Given this list of marker genes Lama2, Glipr1l1 (GLI pathogenesis-related 1 like 1), Tspan32, Ctla4, Nrxn1, Itga10, Itga11, Itgb4, Itgal, Itgad, Nid1, Mmrn1, Itga2b, Cd28, Itgb6, Itgam, Lgals1, Jam2, Nlgn1, Itgax, Itgb1, Itgb8, Lamb2, Itga9, Emilin1, Plp1, Lamc1, Itgb2, Itga1, Tnn, Vtn, Itgb7, Lama1, Lyn, Tnc, Emilin2, Lgals2, Itgav, Itgbl1, Plau, Cd80, Itga4, Itga7, Itga6, Itgb5, Izumo1, Itgb2l, Plaur, Pmp22, Tnr, Itga2, Jam3, Itgb3, Itga3, Mmrn2, Lamb1, Itga5, Itga8, Itgae, here is a description of the gene set: Any protein complex that is capable of carrying out some part of the process of cell adhesion to the cell matrix or to another cell. Mouse Gene Set: GOCC_PROTEIN_COMPLEX_INVOLVED_IN_CELL_ADHESION studied in species Mus musculus